Given this list of marker genes Itgb8, Mepe, Itgav, Cd248, Clec14a, Gabbr1, here is a description of the gene set: studied in species Mus musculus Binding to a protein that is part of an extracellular matrix. Mouse Gene Set: GOMF_EXTRACELLULAR_MATRIX_PROTEIN_BINDING